Given this list of marker genes Ctla2b, Cd48, Selenos, Cst7, Myl1, Atf7ip, Cpa3, here is a description of the gene set: Mouse Gene Set: KASLER_HDAC7_TARGETS_2_UP Genes up-regulated in DO11.10 cells (hybridoma) by expression of transciptionally activating and by transcriptionally repressive forms of HDAC7. species: Mus musculus Histone deacetylase 7 (HDAC7) is highly expressed in CD4(+)/CD8(+) thymocytes and functions as a signal-dependent repressor of gene transcription during T-cell development. In this study, we expressed HDAC7 mutant proteins in a T-cell line and use DNA microarrays to identify transcriptional targets of HDAC7 in T cells. The changes in gene expression levels were compared to differential gene expression profiles associated with positive and negative thymic selection. This analysis reveals that HDAC7 regulates an extensive set of genes that are differentially expressed during both positive and negative thymic selection. Many of these genes play important functional roles in thymic selection, primarily via modulating the coupling between antigen receptor engagement and downstream signaling events. Consistent with the model that HDAC7 may play an important role in both positive and negative thymic selection, the expression of distinct HDAC7 mutants or the abrogation of HDAC7 expression can either enhance or inhibit the signal-dependent differentiation of a CD4(+)/CD8(+) cell line. from publication Kasler HG, Verdin E (PMID 17470548)